Given this list of marker genes MIR221, NES, CDC73, OPN1LW, ZNF207, RAD51D, SMARCA2, IL1A, CEP120, KIF18B, AURKAIP1 (NCBI Gene Id 54998), ERCC3, PBRM1, CETN2, HAUS5, M1AP, TRIP13, KIF20A, BCCIP, NANOS2, CEP131, MIR520A, PAF1, USP26, TRIAP1, PIBF1, NUDC, DBF4, INO80, CDC7, FBXO5, STK33, NR3C1, MAJIN, CDC14C, ABCB1, KIF23, TOM1L2, CDC20, PARP9, SMC6, RCC1, NPR2, IK, MIR222, RDX, CENPP, FIRRM, PKMYT1, CCNP, CENPF, ROPN1B, FBXO30, TMSB4X, KLHL9, GEN1, TUBE1, PIAS1, NUF2, LYN, REEP4, STRA8, KIF15, HTT, RRP8, ANAPC5, UBE2C, SDE2, IQGAP2, RPA4, MNAT1, TGFA, SRPK1 (NCBI Gene Id 6732), PRPF40A, SEPTIN8, KIF4B, SGO1, DACH1, FEM1B, FBXO43, POLA1, PKP3, MEIOSIN, CNTLN, ID4, ACVR1, NAA10, RFPL1, RPRD1B, CACUL1, SMC1B, MTCL2, CDK10, CDC25A, NFE2L1, HAUS3, CKAP2, USP22, TOP3B, BECN1 (beclin 1), TERB1, BRDT, ARID2, OBSL1, SUSD2, RIOK2, EXOC6B, TPX2, CENPE, MIR873 (microRNA 873), MIR208A, FOXM1, BBS4, NSMCE2, ZW10, KLHL13, PDGFB, TFAP4, RAB6C, APC, CALR, PBX1, SYCP2, USP33, ROMO1, RNF112, EPS8, CCND2, WEE1, CDC16, NCAPD3, SYF2, RHOC, DDRGK1, LSM11, XRCC2, EPGN, BUB1B, ACTR2, AVEN, SETD2, DCTN3, REC114, ARL8A, INIP, KIF2C, RAB11A, CEP192, ETAA1, ODF2, MDC1, SKA1, MUC1, CDC25B, CCDC15, AHCTF1, MOS, CCNQ, DSCC1, EXOC3, GNAI1, TFDP3, SDCCAG8, SMARCA5, RRM1, ZNF655, SLC25A5, ATP2B4, TUBB8, NEUROG1, ANAPC15, DCTN2, CENPX, PPP2R2A, TUBB, SMARCD2, RAD21, KCTD19, DCDC1, PIK3R4, DNM2, SKA2, FES, FGF10, TP63, LATS2, ZFP36L1, AGO4, SPAST, PMF1, OPN1MW, IQGAP1, MAGEA5P (NCBI Gene Id 9174), USP17L2, KAT2B, CYP1A1, SGO2, USP9X, DDB1, NPM1, TPPP, CUL9, IFFO1, MEI1, RXFP3, DDX11L8, UBE2B, NEK6, BCL2L1, MYO16, HUS1, BID, MAD2L1, DOT1L, ATF5, H2BW1, TDRKH, XRCC3, LUZP1, CDKN1C, RPL24, TLK1, ARL3 (ADP ribosylation factor like GTPase 3), PRMT2, MSX2, WDR62, GFI1B, PDXP, RMI2, NAE1, CLASP1, HUS1B, HAUS1, IER3, WAC, TTL, CALM3, RNF212B, PAGR1, MTMR4, JTB, SETDB2, ADAMTS1, E2F1 (E2F transcription factor 1), STK35, ROCK2 (NCBI Gene Id 9475), CAV2, SYCE2, ANXA11, UBD, FBXW5, CIAO2A, PHB2, MACROH2A1, EDNRA, FMN2, KLHL21, MISP, P3H4, NEK7, PPME1, TP53, DMC1, USH1C, TPRA1, SPIRE2 (NCBI Gene Id 84501), STARD9, PRP4K, TACC2, NDC80, CDK14, KIF11, PHF13, GINS3, ZFYVE19, CEP250, MIR214, CDC34, SENP2, RPL10L, OPN1MW2, CCDC66, SPTBN1, USP29, REC8, TRIM37, INTS13, PPP2R1B, ZPR1, EHMT2, LZTS2, ANAPC7, CKAP5, FAM107A, CDK4, CENPO, KIF2B, MDM2, GPNMB, DNA2, TAF10, TRIM71, HAUS8, PRKCA, SYCP1, MME, EREG, SPRY2, XPC, ANAPC11, SPC24, BRSK1, LLGL1, TAF1L, CCSAP, CETN3, MIR29B1, TELO2, BRIP1, ARL8B, CUL3, DPF2, CENPM, GATA6, BORA, ITGB1BP2, C9orf78, MYH10, SLC2A8, PSRC1, OVOL1, CDKN2D, RPL23, CTDSP1, PDE4DIP, CCP110, PDCD6IP, PTPN11, MAD2L2, MIR16-1, PPP1R10, SMARCC1, MCMDC2, FLNA, SEPTIN6, CCNI, TENT4A, CIAO2B, WNT4, CCDC102B, PHGDH, POLDIP2, SEPTIN3, CTDSPL, AICDA, ASPM, TUBGCP3, ACVR1B, CDC42, SEPTIN2, KIF3A, ZMPSTE24, UVRAG, KLF4, HDAC3, LSM14A, HINFP, CENPT, RB1, TUBA1A, ZFYVE26, AURKA, MAP10, CCNA1, PLK3, NEK2, CTC1, RPS3, MLF1, MIS18A, MIR638, KLHDC8B, DBF4B, PDE3A, BCAS2, CUL4A, NDEL1, BMP4, STMN1, CENPH, CDKN2A, EGF, RAB24, CCDC8, CRLF3, SEH1L, ZNHIT1, PLA2R1, ARID1A, KHDRBS1, FBXW7, ECD, KLF11 (NCBI Gene Id 8462), TEX19, RMI1 (RecQ mediated genome instability 1), ZBED3, NUGGC, ESCO1, RBL2, NBN, BIRC6, KIF2A, C2CD3, KLHL18, RANBP1, RRM2B, MRGPRX2, ORC4, SAPCD2, EML4, CSNK2A2, NCAPH2, TPD52L1, DRD2, RCC2, CTCF, ACTR3, CALM1, SYCP3, PLRG1, CRY1, GPER1, CDC27, NTMT1, GINS1, KIF20B, TAF1, LRP5, TAS2R13, KIFC1, CHMP7, ERCC2, SEPTIN12, PCNT, MYH14, NUMA1, CIAO1, NUP43, TK1, CHMP4C, RAD50, TTI1, CCNB1IP1, FEN1, GPR132, SMARCD3 (NCBI Gene Id 6604), MTMR3 (NCBI Gene Id 8897), CDCA8, HSPA1A, KLHL22 (NCBI Gene Id 84861), NEK11, CALM2, BIRC5, INTS3, HMGA2, CCNG2, EML1, ANKRD17, CENPV, IGF2 (NCBI Gene Id 492304), CDC14B, CNTROB, PARD6B, CECR2, KIF13A, MASTL, RMDN1, GIPC1, PHF10, KIF18A, ASZ1, KIAA0753, MSH6, OFD1, CEP126 (centrosomal protein 126), CHMP4B, SPAG5, BANF1, TTC19, ANAPC1, RAD51B, SOX2, VRK1, SETMAR, DYNLT1, CPSF3, AKT1, MIR195, SASS6, ATF2, INS, SMC1A, PPP1R35, NDE1, SIRT1, SEPTIN4, RASA1, DLG1, HORMAD2, DACT1, RTKN, CCNJL, ID2, SYCE3, USP16, EIF4EBP1, PABIR1, GPR3, TDRD12, PPP2R2D, MYC, PLEC, EFHC1, CHMP6, BAZ1B, BTC, DYRK3, RTTN, TOP3A, UNC119, CHMP3 (charged multivesicular body protein 3), TCF3, CCL2, ANKRD53, DDX4, PTPRC, PLCB1, PRICKLE1, STXBP4, HEPACAM2, TFDP1, CNTD1, CEP97, TDRD9, PINX1, UBXN2B, RTEL1, PPM1D, SKA3, SMC2, PARP3, RBM46, TUBGCP6, CAPN3, AIF1, HSPA1B, IHO1, CENPK, SMPD3, KIZ, PUM1, TNF, HSF1, RFWD3, TOP2B, UBB, PSMC3IP, PPP6C, ZNF16, USP28, DYNC1LI1, POC1A, USP51, ITGB1, MEIOC, MAEL, KIF4A, MIR519D, SEPTIN7, ATXN10, CCNL1, CEP295NL, MIR495, NSUN2, DEUP1, RIOK3, ERCC1, BABAM1, CDK11A, NCAPG2, TM4SF5, MIR10A, PRDM9, SFPQ, EIF4G1, MYH9, KNTC1, WASHC5, WNT10B, TTN, ATRIP, MDM1, CDKN3 (cyclin dependent kinase inhibitor 3), TERF1, KIF14, CCNB2, RBM14, SNX9, CHMP2A, OR2A4, PTPN6, PPP2CA, PKHD1, CDCA5, MCMBP, CCNH (NCBI Gene Id 902), PLK4, GIT1, SLC25A31, TERT, SPRY1, MIR15A, MAPRE1, MIR133A1, ARHGEF10 (Rho guanine nucleotide exchange factor 10), MIR362, ENSG00000266560, CHMP1A, MIR515-1, CROCC, DTX3L, SAC3D1, MAPRE3, TEX14, CHEK1, CXCR5, GTF2B (NCBI Gene Id 2959), MYB, CDK2AP2, SPDYA, SYCE1, CENPU, DPF1, ANKFN1, PPP2R1A, CTNNB1, CUL5, SEPTIN1, PIWIL2, TLE6 (TLE family member 6, subcortical maternal complex member), CCDC42, CHMP5, CDK2, PPP1R9B, ZNF365, UBE2S, NPPC, NPAT, RAE1, ATR, ATAD5, CCNF, TIPIN, CCNO, CCNB3, BRCA1, DDX3X, CUL4B, ANAPC2, VCP, HAUS6, HOXA13, CDKN1A, CETN1, RANGRF, BROX, ADAM17, RAB35, CENPN, DPF3, EME2, WASL, CHTF8, NPM2, MBTPS1, CLASP2 (cytoplasmic linker associated protein 2), NFIA, DGKZ, ACTL6B, CTDP1, DSN1, SUN1, CLOCK, ZNF830 (NCBI Gene Id 91603), UHRF1, KAT5, MAPK14, CUL7 (NCBI Gene Id 9820), MAP3K20, MELK, WRAP73, TAOK2, SPICE1 (NCBI Gene Id 152185), DRG1, KLHDC3, ILK, CEP55, FBXO6, MOV10L1, SOX15, SMC3, MIR193A, SEPTIN14, ZWILCH, ENTR1, SBDS, TP53BP1, PCLAF, TACC1, NOP53 (NCBI Gene Id 94457), AKAP8L, OOEP, MIIP, CEP295, AUNIP, ZNF324, AURKC, UBE2I, LEF1, ECT2, FBXL7, CSAG1, CDK18, REEP3, SSTR5, ARF6, BARD1 (NCBI Gene Id 580), SNX33, HJURP, APPL1, PRC1, DCTN6, CDK3, TOPBP1, TXLNG, CDC23 (cell division cycle 23), DNMT3L, NANOGP8, ACTL6A, TUBB1, ENKD1, OIP5, CCDC61, PDGFRB, SUGT1, CYP26B1 (cytochrome P450 family 26 subfamily B member 1), MCPH1, PIM2, SMARCE1, CDK11B, ATM, CDK5R1, NDC1, RAD54L, CDC14A, YTHDF2, HLA-G, SIRT7, INSR, PSME3, EZR, CDK15, MIR30C2, FIGNL1, CHAMP1, STAMBP, NSFL1C, DDX11, CCDC57, PKIA, PSMG2, TGFB1 (NCBI Gene Id 7040), E2F8, ZBTB17, TERB2, FBXW11, UBE2E2, FANCM, TAOK3, SPATA22, NEK10, SENP6, PAFAH1B1, CACNB4, SH2B1, ANKK1, MRE11, IL1B, CDK5RAP3, PCM1, EXOC6, CDT1, CHMP4A, BEX4, EME1, FOXJ3, TEX12, TMOD3, TAOK1, KMT5A, BNIP2, KANK2, ANLN, CAMSAP3, PPP1CC, ANAPC4 (NCBI Gene Id 29945), CSPP1, SON, EXOC4, BCAT1, MYBL2, TUBGCP4, LSM10, TMEM14B, CCNJ, CTDNEP1, SLC16A1, MAD1L1, NCAPH, PTTG3P, TNKS, LSM14B, MIR29A, OR1A2, BCL7C, ARID1B, ANKLE1, CCNC, INSM1, E2F7, NFIB, ALMS1, LATS1, CEP44, LIMK2, NUDT16, MN1, ROCK1, BRD4, GADD45A, SLF1, AXIN2, PRKDC, NUSAP1, TTI2, GPR15LG, FGFR1, TUBG1, DMRTC2, TEX15, SFRP1, GIGYF2, STOX1, SNX18, MEIKIN, ZSCAN21, MIR26A1, MYBBP1A, E2F3, ABRAXAS2, SPC25, PHIP, AAAS, PAX6, SPHK1, CDK16, PDS5A, GLI1, FBXO31, EXOC7, KIF3B, PAXIP1, HORMAD1, BRME1, WNT16, ARL2, MIR892B, WDR76 (WD repeat domain 76), EXOC5, POC1B, CDK1, NAA50, MIR451A, SVIL, MARK3 (NCBI Gene Id 4140), MKI67, CHD3, MCM4, MIR15B, SYCE1L (synaptonemal complex central element protein 1 like), FBXO4, NAT10, CAMK2A, SEPTIN10, RAD51, CSNK2A1, CEP68, CHFR, EDN3, PPP2R5B, TOP1, EML3, EXOC8, PSMA8, RAD9B, INHBA, NABP2, PKD2, HDAC8, RPS27L, MIR199A1, GJA1, SMARCA4, PIN1, SMARCAD1, CENPQ, CENPJ, SERPINE1, C1orf146, TUBGCP5, MLH1, TRAPPC12, SIRT2, PDS5B, FOXO4, FAM110A, TMEM67, CEP63, ITGB3BP, GPSM1, WDR90, INTS7, TRIM39, ORC1, PARD6A, TAF2, INCENP, RHOB, SND1 (NCBI Gene Id 27044), RBL1, MSH4, CATSPERZ, MCM3, CEP152, NME6, NCOR1, HAUS4, BCL6, JADE1, BCL7B (NCBI Gene Id 9275), DCUN1D3, WNT5A, RHOA, TESMIN, STAG2 (STAG2 cohesin complex component), MSH2, WRN, LIG1, FOXJ2, PTPA, MIR21, CDC45, TERF2, MMS19, EXOC2, FAM83D, UBE2A, BRCC3, MBLAC1, CRNN, USP50, DMRT1, ZNF503, KDM8, KCNH5, SUN2, MIR133B, CEP72, MTBP, TRIM36, GEM (NCBI Gene Id 2669), LIN37 (lin-37 DREAM MuvB core complex component), CD28, POGZ, CHEK2, DAPK3, KCNA5, TOM1L1, KNSTRN, PCNA, MTA3, ERCC6, INSM2, RAD51C, PPP2R5C (protein phosphatase 2 regulatory subunit B'gamma), CCNB1, BTBD18, E4F1, NUBP1, TLK2, EDN1, CCAR2, PIK3C3, MAP4, RAD18, KNL1, DDX12P, PKD1, LIF, KASH5, CENPA (NCBI Gene Id 1058), DUSP1, KIF22, DDR2, GTPBP4, RAD21L1, MSH5, INPPL1, SEPTIN5, CCNA2, DLGAP5, MIR520H, RGS14, SPDL1, CEP76 (NCBI Gene Id 79959), MIR19B1, TEX11, CCNG1, DCAF13, PROX1, CDK5, PTTG2, POLE, SKP2, CUL1, MAP9, SMC5, CENPI, TTK, STAG1, MAD2L1BP, RINT1, ING4, USP44, CENATAC, DIS3L2, ATRX, HSPA2, CCNE2, GSPT1, EIF2AK4, BOD1, IQGAP3, MEI4, MEPCE, CIT, KIAA1614, APPL2, L3MBTL1, BCL2, GPSM2, TICRR (TOPBP1 interacting checkpoint and replication regulator), RPS6KA2, HASPIN, DBX2, SLC39A5, DUX4, FSD1, CENPS, AFG2B, CYP27B1, CCDC69 (coiled-coil domain containing 69), CHORDC1, HECW2 (HECT, C2 and WW domain containing E3 ubiquitin protein ligase 2), ZWINT, SLX4, ZC3H12D, NDP, USP37, SPO11, SH3GLB1, PSMD13, BIN3, MBTPS2, RAB11FIP3, BMP7, ING2, APBB1, DCTN1, LLGL2, KATNB1, EZH2, TCIM, PHOX2B, PTEN, TREX1, FGF8, VPS4A, BCL7A, RPTOR, MSX1, SSX2IP, CENPC, PARD6G, DTL, RAD54B, NUP37, ERCC4, NLRP5, SHOC1, USP8, FOXN3, MUS81, CDK6, MIR503, PRKCE, RAN, TIMELESS, NABP1, ANXA1, RRS1, UPF1, MLH3, ARPP19, PRPF19, LMNA, EXOC1, STK38, RHNO1, WAPL, EGFR, ACTB, TBX20, RAD17, TOP6BL, GNB1L, POC5, MED1, APBB2, PLK1, UIMC1, CHMP4BP1, UFL1, NOX5, BAG6, GOLGA2, H2AX, CDKN2B, PUM2, STRADA, C14orf39, BLM, ABRAXAS1, PPP2R5D, WIZ, SMARCD1, SMARCB1, PRMT5, RTF2, TRIM75, MAPK15, PSME2, CCNY, KMT2E, CHMP1B, XPO1, SEPTIN9, ZNF541, YTHDC2 (NCBI Gene Id 64848), FANCD2, MARF1, RECQL5, RBBP8, RACGAP1, PPP3CA, FBXO7, PTTG1, CDC25C, CDK5RAP2, AURKB, CENPL, ANK3, PLCG2, TBX2, RNASEH2B, PRAP1, SPIRE1 (NCBI Gene Id 56907), EIF4E, MYBL1, CDC6, BUB1, PHF8, CDKN2C, LPIN1, RAD51AP1, RRM2, CCND1, BIN1, ENSA, MAU2, ARF1, BRSK2, WEE2, HAUS7, UBR2, NAA60, DONSON, CCNL2, PKN2, CTDSP2, PTENP1-AS, RNF212, CSNK1D, CDKN1B, MCM2, PDIK1L, ECRG4, NIN, CDK17, PLK5, CCND3, WDR6, CDC5L, TPR, STAG3, RGCC, HAUS2, TACC3, TOP2A, SHCBP1L, NIPBL, BCL2L11, SLFN11, CLTC, HEXIM2, RHOU, STK11, CDK7, MRNIP, PRKCB, MIS12, KIF25, RPS6KB1, ANKLE2, SEPTIN11, MITD1, MARK4, RAD9A, NCAPG, BRCA2, MAP3K11, STIL, DYNC1H1, SLF2, AKAP8, BTN2A2, CUL2, SPART, HNRNPU (heterogeneous nuclear ribonucleoprotein U), PPP1R12A, MCM6 (NCBI Gene Id 4175), PSME1, MAPRE2, BRD7, BUB3, CCNE1, DAB2IP, NSL1, IST1, PLK2, TUBG2, FZR1, MTCL1, CLSPN, MIR137, MZT1, FANCA, SMC4, ESCO2, SIX3, NUP62, RPA2 (replication protein A2), GMNN, DIAPH3, MND1, CFL1, MIR424, MIR372, HSF5, RNF4, DAZL, CENPW, KAT2A, C10orf90 (NCBI Gene Id 118611), MIR29C, HFM1, PKP4, SOX9, ESPL1, ZCWPW1, TUBGCP2, BABAM2, CCNI2, RIPOR2, MEIOB, KPNB1, FBXL15, TBCE, MYO19, HSF2BP, ZFP36L2, RAD1, UBE2L3, CKS2, TAS1R2, ANKRD31, UXT (NCBI Gene Id 8409), USP19, FHL1, WNK1, CDCA2, CHMP2B, SIN3A, DRD3, VPS4B, CEP135, NCAPD2, IGF1, LCMT1, MAP1S, SMARCC2, PLSCR1, RAB11FIP4, RASSF1, ALKBH4, TIPRL, AMBRA1, CEP85, here is a description of the gene set: The cellular process that ensures successive accurate and complete genome replication and chromosome segregation. studied in species Homo sapiens Human Gene Set: GOBP_CELL_CYCLE_PROCESS